The following is a description of a gene set: Human Gene Set: STEIN_ESRRA_TARGETS_UP Expression of estrogen-related receptor alpha (ERRalpha) has recently been shown to carry negative prognostic significance in breast and ovarian cancers. The specific role of this orphan nuclear receptor in tumor growth and progression, however, is yet to be fully understood. The significant homology between estrogen receptor alpha (ERalpha) and ERRalpha initially suggested that these receptors may have similar transcriptional targets. Using the well-characterized ERalpha-positive MCF-7 breast cancer cell line, we sought to gain a genome-wide picture of ERalpha-ERRalpha cross-talk using an unbiased microarray approach. In addition to generating a host of novel ERRalpha target genes, this study yielded the surprising result that most ERRalpha-regulated genes are unrelated to estrogen signaling. The relatively small number of genes regulated by both ERalpha and ERRalpha led us to expand our study to the more aggressive and less clinically treatable ERalpha-negative class of breast cancers. In this setting, we found that ERRalpha expression is required for the basal level of expression of many known and novel ERRalpha target genes. Introduction of a small interfering RNA directed to ERRalpha into the highly aggressive breast carcinoma MDA-MB-231 cell line dramatically reduced the migratory potential of these cells. Although stable knockdown of ERRalpha expression in MDA-MB-231 cells had no effect on in vitro cell proliferation, a significant reduction of tumor growth rate was observed when these cells were implanted as xenografts. Our results confirm a role for ERRalpha in breast cancer growth and highlight it as a potential therapeutic target for estrogen receptor-negative breast cancer. species: Homo sapiens from publication Stein RA, Chang CY, Kazmin DA, Way J, Schroeder T, Wergin M, Dewhirst MW, McDonnell DP (PMID 18974123) Genes up-regulated by ESRRA only., and this is the list of marker genes: TRIM14, ZNF44, SULT1A2, MECR, DDIT3, SIK1, CYP24A1, YJU2B, PRSS22, DFFA, NQO2, SLC46A3, ATP5PF, CKB, RAB35, MDH1, B4GALT5 (beta-1,4-galactosyltransferase 5), JMJD6, SLC31A1, MTARC2, VEGFA, IQSEC1, SIKE1, CMC2, FDX1, OPA1, PPIC, PFKM, CYP27B1, GAS6, LIFR, OXA1L, RNF34, ECI2, MMACHC, MITF, HOOK1, YIPF2, ILVBL, GOT2, C4orf19, PPIF, UAP1L1, SUPV3L1, NDUFS3, LETMD1, CLEC16A, MRPL4, MGST3, AHCYL1, SLC2A6, SLC25A3, ANKRD28, OR7E14P, VDAC2, PPP2R2D, TCIRG1, GTPBP8, ALAS1 (NCBI Gene Id 211), SLC25A12, SYNGR1, PLEKHB2, ZNF576, FOXD1, MGST2, MRPS11, NDUFA9, ATP5PO, NNT, SDHB (NCBI Gene Id 96200), PDSS1, QRSL1, ARFRP1 (NCBI Gene Id 149661), LPCAT3, RAPGEF6, EBP, NUCB1, GABARAPL1, FSCN1, SLC16A1, EIF3K (NCBI Gene Id 55373), MRPS12, SMC2, HK1, CLUH, RBM7, CIAPIN1, NDUFS1, UGP2, GSTM1, CYTH1, VWA8, ABCB7, STEAP3, TACO1, SMIM8, TWF2, SPTLC2, CRNKL1, UBAC1, ISOC2, PAFAH2, DLD, NDUFA10, HPN, IMPA2, PDHA1 (NCBI Gene Id 5160, pyruvate dehydrogenase E1 subunit alpha 1), CISD1 (CDGSH iron sulfur domain 1), MRPS22 (NCBI Gene Id 64953), MIEF1, ESRRA, ISCU (NCBI Gene Id 91850), ALDH3A2, AMPD3, WDR45, ATP1B1, EGLN1, PLA2G12A, PLGRKT, ACACB, ANXA6, WWC1, GRK4, ECSIT, SCML1, ABLIM1, ABCB9, FA2H, PCYT2, KCNN4, MFN2, TMEM184C, ZNF43 (NCBI Gene Id 7594), SEC14L2, RTL8C, RNF139 (NCBI Gene Id 11236), NECAB3, PGM1, UST, ACAA1, NDUFB5, KCNK13, USP4, FH, BDH2, HMOX2, GPI, IMPA1, GOT1, IMMT, ACADM, RNASET2, TMEM132A, NDRG2, FANCF, MLYCD, MAP1B, NSUN3, INPP1, CKMT2, STN1, MPC1, SEC23B, EGLN3, MED9, TIMM17A, SLC25A4, SULT2B1, NUDT3, TBX2, UQCRC1, EHHADH, MMP9, GAS2L1, RAP1GAP2, DUSP22, ALDOC, MPC2, DLAT, DSG2, NDUFS7, DCTPP1, FAM50B, GSTK1, SLC38A7, APOO, RAB21, RALA, PLCXD1, UQCRC2, SIRT5, RAP1GAP, CS, EPN3, IVNS1ABP, FAHD2A, MRPL2, DUSP1, MCF2L-AS1, SLC25A40, TIMM50, SOD2, GMCL1 (germ cell-less 1, spermatogenesis associated), RBM38, STX18, SDHD, COX5B, EPOR, ATP5MC3, VPS9D1, NAGPA, CAPRIN2, DGAT1, COX7B, LEFTY1, SUCLA2, ATP5F1C, IDH3A, CYCS, CA12, COQ3, CALU, DLST, FAM162A, PSG9, SLC25A20, MRPL11, ST6GALNAC4, HTATIP2, SUCLG1, MFF, FBXL15, MRPL35, TBC1D31, EMC3, CASP9, ST3GAL5, ACYP1, SPINT1, NDRG4, ETFDH, TRIM2, COX10, MANF, SLC10A2, MDH2, TJP3, AURKA, ATP5MG, NDUFV1, CPTP, AIFM1 (NCBI Gene Id 9131), CPT1A, MTRF1, ACADSB, COA1, SAMM50, TMC6, MARCHF3, FDXR, OPLAH, AKAP1, RHOQ, ATP5MJ, MRPS30, CHCHD3, NDUFS2, CAAP1, SOCS2, RNF4, TMX4, ENDOG, COX5A, NDUFAF4, ZNF165, SLC16A3, GFPT2, CTSL, CFLAR, RAB17, PEX26, NDUFA8, GDF15, GSTM4, AFG3L2, DECR1, ELP5, RNF14, RETREG1, NPM3, ACAT1, ARL2BP, GM2A, UQCRFS1, MATK, PPP1R13L, NXF1, THAP4, EPAS1, TRAK2, VPS26C, OGDH, AK1, RPS6KA1, MAEA, PDCD10, MRPL15, OTUB2, MRPL34, UQCRB, GRPEL1, PXMP4, SH2B1, RGP1, MMUT, MIPEP, NPR3, MINDY1, TRIM52, ATP6V0E2, HIGD1A, PLIN3, TACC2, DHDDS, ATP2A3, SDHA, CCDC121, CTSC, ACAA2, DHRS11, KIAA0040 (KIAA0040), ZBTB43, ZNF768 (zinc finger protein 768), PCTP (NCBI Gene Id 94001), RASA4, SCAMP5, WIPI1, RNF5, NANS, SETMAR, PDHX, RHOF, FASTKD1 (FAST kinase domains 1), ACY1, NDUFS8, TOMM70, MTX2, TRPC1, NFU1 (NCBI Gene Id 80767), GK, TMT1A, OPN3, AP5M1, CEP70, CYP1A1, ORC2, PRPSAP1, HCCS, IFT27, OSBPL1A, ISCA1, ETS2, VDAC3, QARS1, PFKP, ZNF750, ZNF669, ECI1, KIF3B, IDH3B, MAFB, ACO2, ASNS, SYNGR3, ADCY1, PCGF1, SRPK2, TEX2, FOXC1, AFF1, CKMT1B, NDUFS4, COQ9, TIMM8A, ATP5MC1